Given this list of marker genes Bpnt2, Pgap2, Dpm3, Gpaa1, Inpp1, Atm, Pigk, Pdgfa, Pigh, Inpp4a, Pigo, Impa2, Pi4ka, Pik3cg, Pyurf, Inppl1, Mppe1, Pdgfb, Plcg2, Pigg, Pigz, Pik3cd, Cwh43, Ip6k2, Slc27a1, Pip5kl1, Pik3c2b, Pik3cb, Pip5k1c, Itpkc, Pip4k2b, Ptprq, Pik3r4, Pik3c3, Slc30a5, Tmem150a, Hycc1, Smg1, Htr2c, Inpp4b, Ttc7, Pgap4, Pigx, Dgke, Efr3b, Pgap1, Becn1, Dpm1, Uvrag, Atg14, Vac14, Pigm, Pigl, Pip5k1a, Pi4k2a, Pigyl, Htr2b, Pik3ca, Pigw, Pip5k1b, Pigb, Pigc, Itpka, Bpnt1, Pigs, Ip6k3, Pigt, Htr2a (NCBI Gene Id 239184), Pgap3, Mboat7, Itpkb, Hycc2, Impa1, Pik3r1, Pigq, Pigu, Inpp5e, Pi4kb, Sh3yl1, Pip4k2a (phosphatidylinositol-5-phosphate 4-kinase, type II, alpha), Pik3c2a, Pik3c2g, Pi4k2b, Pigv, Fig4, Dpm2 (dolichyl-phosphate mannosyltransferase subunit 2, regulatory), Cdipt, Ttc7b, Pip4k2c, Ip6k1, Pigf (NCBI Gene Id 18701), Pign, Pigp, Cds1, Piga, here is a description of the gene set: Mouse Gene Set: GOBP_PHOSPHATIDYLINOSITOL_BIOSYNTHETIC_PROCESS studied in species Mus musculus The chemical reactions and pathways resulting in the formation of phosphatidylinositol, any glycophospholipid in which the sn-glycerol 3-phosphate residue is esterified to the 1-hydroxyl group of 1D-myo-inositol.